Given this list of marker genes PRKAR1A, TP53, PDE11A, MST1R, STK11, here is a description of the gene set: studied in species Homo sapiens Human Gene Set: HP_NEOPLASIA_OF_THE_NASOPHARYNX Neoplasia of the nasopharynx